The following is a description of a gene set: Human Gene Set: BENPORATH_SOX2_TARGETS from publication Ben-Porath I, Thomson MW, Carey VJ, Ge R, Bell GW, Regev A, Weinberg RA (PMID 18443585) studied in species Homo sapiens Set 'Sox2 targets': genes upregulated and identified by ChIP on chip as SOX2 transcription factor targets in human embryonic stem cells. Cancer cells possess traits reminiscent of those ascribed to normal stem cells. It is unclear, however, whether these phenotypic similarities reflect the activity of common molecular pathways. Here, we analyze the enrichment patterns of gene sets associated with embryonic stem (ES) cell identity in the expression profiles of various human tumor types. We find that histologically poorly differentiated tumors show preferential overexpression of genes normally enriched in ES cells, combined with preferential repression of Polycomb-regulated genes. Moreover, activation targets of Nanog, Oct4, Sox2 and c-Myc are more frequently overexpressed in poorly differentiated tumors than in well-differentiated tumors. In breast cancers, this ES-like signature is associated with high-grade estrogen receptor (ER)-negative tumors, often of the basal-like subtype, and with poor clinical outcome. The ES signature is also present in poorly differentiated glioblastomas and bladder carcinomas. We identify a subset of ES cell-associated transcription regulators that are highly expressed in poorly differentiated tumors. Our results reveal a previously unknown link between genes associated with ES cell identity and the histopathological traits of tumors and support the possibility that these genes contribute to stem cell-like phenotypes shown by many tumors., and this is the list of marker genes: APP, HIKESHI, PSMC2, RAB3GAP2, TRIR, IER5L, APEX1, INO80D, RDH11, UIMC1, DUSP6, MORF4L1, DARS2, EEF2, PTPN3, BCLAF1, HNRNPC, RMI1, IDH3G, SLC3A2, FZD10, PPP2R3A, CDYL, GUCD1, BUB3, ACTMAP, SASH1, CAPRIN1, AP3B1, HMG20A, RPS18, PGAP3, RESF1, LRAT, RASGRF2, DDX21, VRTN, PCSK5, CFAP20 (NCBI Gene Id 29105), BCKDHA, NDUFA11, MRPS11, NME7, RIPK1, SLC38A2, SGMS1, MED25, ZNF516, RPS3A, PUM1, KIF15, TMEM245, ZIC3, URM1, KDR, OLFML3, CDK6, PRCC, TAL1, C1orf21, SRSF7, LRP2, ZNF331, HSP90B1, RBM22, DDX39A, FBXL19, PRPSAP1, EGR3, VCPKMT, FOXN3, FZD7, ADAR, NFE2L3, PSEN2, RIC8B, TCF20, RAB4B, USP7, MSL3, PDCL (phosducin like), MSC, UBR1, C12orf60, MLH1, POU5F1, TIA1, STAP2, SPCS2, FZD3, ZSCAN2, DSCC1, DDX17, LOXL2, PSMB1, CDH3, KCNN2, AAMDC, PDPN, MORF4L2, BMP2, CBX3 (chromobox 3), LSG1, DNAJC16, DHX38, BMP7, HSD17B12, SORT1, AP5M1 (adaptor related protein complex 5 subunit mu 1), RANBP10, MEX3C (NCBI Gene Id 51320), RRS1, UFD1, ATP5PB, AMOTL1, OSGEP, MTF2, TUBB, IFI16, CLIC4, VPS35, LSM3, GPC6, DUSP12, HNRNPUL1 (heterogeneous nuclear ribonucleoprotein U like 1), ATF3, PPP2R5C, DNAJC2, CIAO2A, NOC3L, C1orf174, MKKS, VASH2, TSC22D1, ZNF281, GRHL2, PNMA1 (PNMA family member 1), HAS2, PITX2, SPAG9, VAT1, TGIF2, ZEB2 (NCBI Gene Id 9839), SCNN1A, AKT1S1, DDX5, RASL11B, PPP1R15A, TRPC4AP, TDRP, PPM1B, IGFBP2, BDH2, FIP1L1, SLC39A1, SLC7A5, AKIRIN2, CABLES1, ZCCHC14, ELP6, PRDM14, SMARCAD1, AASDH, KIF2C, LEFTY2, CISD1, TIAL1, RBM39 (RNA binding motif protein 39), SP2, IK, CER1, TUBG1, MAN2C1, PRKAR1A, AJUBA (NCBI Gene Id 84962), FBXL14, ABLIM1, MTM1, DHRS3, SDCCAG8, WDR36, UBE2D3, TBC1D10B, KCNMB4, MYNN, NUFIP2, TRA2A, MCTS1, ZNF217, THBS2, ILF2, ARF4, ETHE1, SC5D, SLC44A1, CFL1, AVEN, SENP2, FZD1, KIF11, VCAN, GET3, ACO2, BCL9, NOL6, ELAVL2, AK3, USP25, GRK6, TMEM170A (NCBI Gene Id 124491), CRIM1, ZNF701, H2BC21, ID1, TRIM16, SFPQ, NSUN3, TCAF1, UFM1, JADE1, DKK1, ZFP36L1, E2F3, VPS52, SCG3, MINDY2, OAZ2, EXOC5, FGFR2, POLR3E, PCF11, H2AC25, INO80C, TIMM9, CACNA2D1, AGO2, PPP1R10, XAB2, PIP5K1C, H4C3, C20orf96, STXBP2, HBP1, PRPF19, PRDX1, TLE1, PER2, CTH, HDAC9, FEM1A, RAB15, ARID1B, NUCKS1, KLF5, ORC1, VWA5A, EXPH5, ERRFI1, UBE2T, NAALAD2, TMEM108, KLHL5, ZCCHC3, TIMM8B, PPM1N, SEPTIN6, PARG (poly(ADP-ribose) glycohydrolase), TEAD2, OGT, ECPAS, DGLUCY, POLE3, CALR, HDGFL2, COL12A1, ABTB2, NUDT4, NAXD, RASA1, ARL4D (ADP ribosylation factor like GTPase 4D), TARBP2, FAXDC2, ZNF646, NDUFB5, RTN2, HDAC2, ZNF286A, POLR3G, CETN3, SAV1, YJU2, MRPS31, TRIT1, CBY1, SKA2, GXYLT1, ZIC2, PRSS8, CEP41, AQP2, PTPN2, CNOT8 (CCR4-NOT transcription complex subunit 8), PPP2R3C, OSBPL1A, FOXJ2 (forkhead box J2), KIF20B, SAP30, ACOX1, DVL2, LINGO1, RBBP9, NEDD4L, NUP160, TJP3, NSD3, NIP7, SNRPD3, TBL1XR1, PSMG2, ABCF2, KIAA1143, FOXO1, TAF12, ARID5B, BUB1B, ARIH1, GFOD3P, MRPS23, ZFYVE19, FANCC, BAMBI, SDE2, PNISR, DPPA4, KIAA0319L, DTNA, DPH6, GGA1, REST, FBXO16, UBE2W, SCAF1, PAXBP1, PIH1D1, EPM2AIP1, KATNBL1, FTL, DCAKD, SGK3, ATP6V1G1, DPYSL2, SINHCAF, SGTA, MRPL43 (NCBI Gene Id 84545), CDH2, ARF3, MRPS27, FAM76B, MOSPD3, SMIM3 (NCBI Gene Id 85027), DIAPH3, CPT1A, ERBB2, CRIPTO, TALDO1, ARHGAP1, SAT1, PIP4P1, GGPS1, SMG7 (SMG7 nonsense mediated mRNA decay factor), LRRN1, RDH10, PNP, EXOSC9, ABCB7, TCF7L2, WBP11, ZNF668, CAVIN3, NANOG, RPS29 (ribosomal protein S29), ENPP2, TLE2, ZIC1, HSPA13, MTSS1, DIDO1, COA7 (cytochrome c oxidase assembly factor 7), GBF1, SCAF4, BCAT1, ZNF335, PIPOX, ING4, SUGP2, ZNF428, CLP1, CDK14, ARID4B, TNFAIP2, ABHD11, STC1, FAM98A, MAPRE2, RAD23A, RAD54B, CALM2, CBX5, POLDIP3, CAPZA2, PHF23, HNRNPL, UQCR10, HNRNPA2B1, SNRPN, EPHA1 (EPH receptor A1), SFRP2, HMOX1, NBR1 (NBR1 autophagy cargo receptor), IRX2, LSM4, SH3GL3, GADD45G, PLPP1, ORC6, KPNA3, JARID2, TLE3, RFX1, XRRA1, RNF24, ATAD2, KIFBP, B3GALT4, PIN4, FOXP1, CEP89, PGM2L1, LRFN3, TNC, TXNDC12, PHF8, DHDDS, NEBL, CDC14B, TAF15, TNRC6A, CEP95, SRSF4, H2AX, ATF4, FANCF, EIF4G2, PLIN2, ARHGAP11A, KDM3A, MED17, PRNP, MUS81, RRN3, NMU, SF3B5, SLC7A5P2, DPAGT1, FUS, ANKRD1, RPS26, ARFGEF1, SSBP3, UBP1, LYPD1, FICD, USP44, HSP90AB1, ICMT-DT, TRIM24, DCAF11, NIT1, ICMT, H2AC18, UGT8, GDAP1, LARP7, HNRNPK, DPP3, NBAS, LASP1, TBP, SPIRE1, MAP3K12, GSPT2, MDC1, MRPL47, NDUFA2, FGFR1, FBXW11, LEFTY1, ALCAM, TBC1D17, ODF2L, CXCL5, SUFU, SLC7A11, TMEM160, ST3GAL2, SUSD6, CLN3, CDC42BPA, ANP32A (acidic nuclear phosphoprotein 32 family member A), AKIRIN1, JPT1, ZNF140, ADGRL1, ENSA, TXNRD1 (NCBI Gene Id 7296), HEXIM2, ARRDC3, RBPMS, ANKHD1, RPL9, COPS7A, RSF1, DPYSL3, C1orf54, FZD2, CCND1, ZNF300 (zinc finger protein 300), TRIML2, TIMM23B, OARD1, DDA1, CDK17 (NCBI Gene Id 5128), SKIL, GNPTAB, RBM23, MAST1, EMC9 (ER membrane protein complex subunit 9), GRK3, LHPP (phospholysine phosphohistidine inorganic pyrophosphate phosphatase), CA4, KAT6A, RIF1, VIM, FARSA, HUWE1, TCF7L1, GTPBP3, FGF2, VASP, SNAPC1 (NCBI Gene Id 6617), TMSB10, FEZ1, CDC7, SSR4, NKIRAS1, CACHD1, NUSAP1, CDC45, CSNK1E, IWS1, NEMF, KNTC1, HESX1, RPLP1, COMMD3, ACTR1A, LARGE1, C14orf119, ALDH7A1, PRPF38A, SNRPA, CYB5R2, MPND, RNF31, STAT3, G3BP1, PRORP, ZNF677, BTG1, PIF1, THOP1, SDHD, ILF3, TIMP4, COPB1, SCNM1, MAT2B, SLC7A5P1, KANK1, SNAPC3, SMAD3, PRR11, PWP1, OGA, ARMC6, CACNA1A, GSK3A, GNAI1, CDK16, ANO8, WDR77 (NCBI Gene Id 79084), ZNF770, SNX1, RSRC2, SET, ZC4H2, PLEKHG3, MAP3K11, TMEM63A, GSK3B, ZIK1, PLPP5, PPP1R2, COMMD7, RAB25, PAK1, APH1A, RNF14, FXYD5, CA2, USP49, HLTF, SALL1 (spalt like transcription factor 1), MLLT10 (NCBI Gene Id 8028), SERPINA1, WDFY2, PPP1R11, EIF3F, GNG10, POU2F1, RGS10, H3-3B, GNA13, ALPL, NAA30, ZCRB1, TRIM22, TTF2, HNRNPA1, DNAAF9, BTF3L4, ROR1, PRKRIP1, NCDN, EXOSC5 (NCBI Gene Id 56915), TSTD2 (thiosulfate sulfurtransferase like domain containing 2), CCN2, PCNX3, TMEM109, PPP2R1A, MED12, MRPL15, DNM2, TOP2A, CEP131, NCBP1, HELLS, MAGED2, TIPIN, RAB5A, HMBOX1, ADD3, OXA1L, CDK1, RAB17, SOX2, ANP32B, GRID2, SEMA6A, MOBP, UBC, AUH, SFRP1, UBQLN4, UBR5, RCOR3, NKTR, OBSL1, ZNF664, RPL36A, TPM3, PHAX, RPL15, LAMA4, EOMES, RPL30, LAMTOR2, GJA1 (gap junction protein alpha 1), NDUFB8, PCBP1, HHEX, JUP, SFXN1, FAM124A, UBE2C, RETREG3, CREB3L4, SULF1, PLEKHA3 (NCBI Gene Id 65977), CASP9, HEPH, ACOT8, UBALD2 (NCBI Gene Id 283991), OBI1, HECTD2, NOTCH1, FAM168A, KIF26A, SPRED1, INHBA, EGLN3, TMEM123, USO1, AP2A1, EAPP, NAA38, CCDC93, WDR81, IGF2BP3, ACIN1, MYO9A, MRPS18B, PIK3R3, PPP2R1B, HIF1AN, FRAT2, RPL7, H2AJ, CCN1, B4GALT6, CDK12, OIP5, PTN, FBXO11